Given this list of marker genes CDK1, ABHD4, HCCS, MKI67, ZNF362, NRP1, BCL2A1, PRNP, GNG2, ODC1, COX6A1, TTC39B, RGS8, ASCL2, PCNA (proliferating cell nuclear antigen), RPA1 (replication protein A1), CKS1B (CDC28 protein kinase regulatory subunit 1B), CD160, MRPL1, ANAPC13, S100A10, SYPL1, CD84, ADAM19, MMD, RRM2 (ribonucleotide reductase regulatory subunit M2), TPX2 (NCBI Gene Id 23477), NFATC1, EGLN3, DPY30, LXN, CLDND1, AURKA, DECR1, CCT2, MARCKSL1, MOAP1, ZFP91, BCL6, RBM18, KPNA2 (karyopherin subunit alpha 2), SOD1, PRR13, CDKN2C, RSPH3, LYAR, ALDH7A1, VPS29, DBI, TIMM17B, HIF1A, LANCL2, ENSG00000286190, TMEM106B, SOSTDC1, GADD45B, CD44, CENPV, CNIH1, TMA7, ACOT4, PAQR4, GPR155, CORO2B, HPRT1, TNFSF8, S100A11, SYNGR2, LGALS1, IL4, RRM1, ACADL, CALHM2, LIG1, ANXA2, CCNB2, CETN3, TJP2, RPN1, TIPIN, HMGB3, PLAGL1 (PLAG1 like zinc finger 1), PGAM1, PTGER2, REG3A, RB1, MRPL18, UBE2L3, TRAPPC1, ACOT7, PRC1, LPGAT1, S100A6, ID2, PLAC8, BHLHE40 (NCBI Gene Id 8553), NKG7, PTP4A2, CDC25B, CXCR5, PTRHD1, GABARAPL1, IDE, NUDT2, IFNAR2, CCNA2, CKS2, SYT11, S100A4, TNFSF11, PPP3CC, ICOS, ANGPTL2, CTLA4, PRIM1, MFSD14A, S100A1, PGK1 (NCBI Gene Id 5230), TOP2A (DNA topoisomerase II alpha), CASP4, LAMTOR5, MAP2K3, FH, DDT, MID1IP1, MCUB, UQCRQ, MMS22L, SLC25A4, ERMP1, MRPL11 (NCBI Gene Id 65003), MDFIC, CXCR3, GALNT2, DNAJC1, ADISSP, BUB1, ATP5ME, TBCB, CASP1, NDUFC2, RORA, BCL2L14, COMMD1, PEAR1, NFATC4, TSPAN5, COA6, TCEAL9, CASP3, EIF2S2, LPXN, TIAM1, TMBIM1, LCLAT1, PLXNC1, GIMAP1, PFN2, EEF1AKMT1, CENPA, HMGB2, PSME3, CEP15, RAD51 (RAD51 recombinase, NCBI Gene Id 5888), MCM5, CD83, HOPX, IL21, GPM6B, TMEM126A, DYNLT3, POU2AF1, NUSAP1, ADAT2, SPRY1, NQO2, SELENOH, ASF1B, GLOD4, CIBAR1, LGALS3, NDUFB7, TIMM23, GLRX3, CYFIP1, VPS36, SASS6, PRDX1, PDPK1, LITAF, CDCA5, REEP5, RWDD4, PCLAF, UBE2C, STMN1, DCTPP1, PDCD6IP, NCAPG, MICOS10, here is a description of the gene set: species: Homo sapiens from publication Westwood JA, Haynes NM, Sharkey J, McLaughlin N, Pegram HJ, Schwendener RA, Smyth MJ, Darcy PK, Kershaw MH (PMID 19996209) Human Gene Set: GSE18203_CTRL_VS_INTRATUMORAL_CPG_INJ_MC38_TUMOR_DN Genes down-regulated in tumors established by injecting MC38 cells (colon cancer): control versus CpG oligodeoxynucleotide 1826. To determine the effect on gene expression of intratumoral injection of the Toll-like receptor agonist CpG1826. MC38 colon cancer cells were injected subcutaneously into C57BL/6 mice and allowed to establish until ~40 mm2.